The following is a description of a gene set: part of: Axon guidance Reactome Pathway: EPH-Ephrin signaling During the development process cell migration and adhesion are the main forces involved in morphing the cells into critical anatomical structures. The ability of a cell to migrate to its correct destination depends heavily on signaling at the cell membrane. Erythropoietin producing hepatocellular carcinoma (EPH) receptors and their ligands, the ephrins (EPH receptors interacting proteins, EFNs), orchestrates the precise control necessary to guide a cell to its destination. They are expressed in all tissues of a developing embryo and are involved in multiple developmental processes such as axon guidance, cardiovascular and skeletal development and tissue patterning. In addition, EPH receptors and EFNs are expressed in developing and mature synapses in the nervous system, where they may have a role in regulating synaptic plasticity and long-term potentiation. Activation of EPHB receptors in neurons induces the rapid formation and enlargement of dendritic spines, as well as rapid synapse maturation. On the other hand, EPHA4 activation leads to dendritic spine elimination.<br>EPH receptors are the largest known family of receptor tyrosine kinases (RTKs), with fourteen total receptors divided into either A- or B-subclasses: EPHA (1-8 and 10) and EPHB (1-4 and 6). EPH receptors can have overlapping functions, and loss of one receptor can be partially compensated for by another EPH receptor that has similar expression pattern and ligand-binding specificities. EPH receptors have an N-terminal extracellular domain through which they bind to ephrin ligands, a short transmembrane domain, and an intracellular cytoplasmic signaling structure containing a canonical tyrosine kinase catalytic domain as well as other protein interaction sites. Ephrins are also sub-divided into an A-subclass (A1-A5), which are tethered to the plasma membrane by a glycosylphosphatidylinositol (GPI) anchor, and a B-subclass (B1-B3), members of which have a transmembrane domain and a short, highly conserved cytoplasmic tail lacking endogenous catalytic activity. The interaction between EPH receptors and its ligands requires cell-cell interaction since both molecules are membrane-bound. Close contact between EPH receptors and EFNs is required for signaling to occur. EPH/EFN-initiated signaling occurs bi-directionally into either EPH- or EFN-expressing cells or axons. Signaling into the EPH receptor-expressing cell is referred as the forward signal and signaling into the EFN-expressing cell, the reverse signal. species: Homo sapiens, and this is the list of marker genes: PSENEN, GRIN1, CDC42, CFL1 (NCBI Gene Id 1072), NCSTN, MYH10, ARPC4, NGEF, GRIN2B, EFNB2, NCK2, EFNB1, CLTC, CLTA, ACTB, SDC2, EPHB3, APH1A, PSEN1, EFNB3, PAK1, RASA1, SDCBP, AP2A1, EPHB6, ARPC2, ROCK2, GIT1 (NCBI Gene Id 28964), ARPC1A, EPHA7, ACTG1, ARPC3, DNM1, PSEN2, HRAS, MYL12A, YES1 (YES proto-oncogene 1, Src family tyrosine kinase), EPHA6, EPHB1 (EPH receptor B1), AP2M1, MYH14, LIMK2, ROCK1, AP2S1, KALRN, ITSN1, EPHA1, EPHB4, MYL9, EPHA5, CLTB, ARPC1B, EPHB2, PAK2, LYN, LIMK1, MMP9, VAV2, WASL, SRC, ARPC5, MYL6, MYH9, AP2B1, MYL12B, CLTCL1, EFNA5, MMP2, ARHGEF28, PTK2, PAK3, VAV3, EPHA4, MYH11, ACTR3, TIAM1, EPHA3 (EPH receptor A3), RAC1, ARHGEF7, EPHA10, EFNA4, EFNA3, ACTR2, ADAM10, FYN, APH1B, EPHA2, EPHA8, EFNA2, AP2A2, EFNA1, RHOA